Given this list of marker genes CRYAB, MAGI2, IGFBP7, ACSM3, CDH1, MPC2, KCTD12 (potassium channel tetramerization domain containing 12), KRT19, TPST1, OXCT1, LLGL2, CAV2, REEP5, MECOM, TEK, FUCA1, LYN, CX3CL1, ATP5MG, ACOT2, SLC22A5, SLC30A1, ETS2, CLU, ALDH6A1, NCOA3, IFIT1, GADD45A, PEX7, SEMA3C, ZEB2, AKR1C3, LAMP2, DUSP9, RAB22A, SYNGR2, CDH5, IL27RA, TACSTD2, HOXD8, SERPINF1, S100A10, LEPROT, KAZN, PDXK, PMP22, GNG12, DST, COL1A2 (NCBI Gene Id 1278), MYOF, DSTN, MAF, PATZ1, FGFR3, FPGT, TRAM2, CLDN3, MTMR6, RGL1, MAN2A1, PGRMC2, TNFAIP8, SELENOP, ERG, ALDH4A1, ELF1, CTSH, ITM2B, NR3C1, GNAI1, THSD7A, CRIM1, TMED5, IQCK, PDE8A, SERINC5 (serine incorporator 5), TCF21, PRNP, RBPMS, SMPDL3A, PPP2R5A, KIF13B, IL10RB, TGFBR2, ZNF44, ALDH1A1, ST3GAL6, ANK3, PLCG2, CTSO, SPP1, GPRC5B, IQGAP1, CPVL, MITF, ATP10D, AGRN, TSPO, TBC1D9, SLC37A4, PDZRN3, PPP1R3C, BPGM, OLFML2A, APOE, PRCP, DAB2, KIFC3, MYLK, ALCAM, HPN (NCBI Gene Id 3249), SEPHS2, LRRC32, EFR3A, TRIM2, APOM, PLS1, FRY, PLAU, SLC35A3, PODXL, SCP2, PRPS2, COL4A5, VEGFA, CA12 (carbonic anhydrase 12), MERTK (MER proto-oncogene, tyrosine kinase), ERBB4, AXL, CRADD, AHNAK, TOM1L1, IMPA2, CTDSPL, DYNC2LI1, MXRA8, KDR, BLVRB, PPL, SP100, CDKN1C, TGOLN2, ZNF124, LDB2, ANGPT1 (angiopoietin 1), PLS3, CRYZ, ATP1B1, ENPEP, PDE6B, XBP1, IL1R1, RIDA, TFPI, HERPUD1, MSMO1, SDHD, TOB1, MYH9, GLUD2, ANXA4, ASAH1, PLPP1, VLDLR, CD2AP, AMOTL2, CDS1, CAST, GNG11, UGCG, FGF9, CEBPD, CYB5A, ACSL1, CARD10, FAM3C (NCBI Gene Id 10447), IQGAP2 (NCBI Gene Id 10788), MATN2, CREBL2, GUCY1A1, ANXA3, ITPRID2, ATP1A1, here is a description of the gene set: Genes up-regulated in Wilm's tumor samples compared to fetal kidney. from publication Li CM, Guo M, Borczuk A, Powell CA, Wei M, Thaker HM, Friedman R, Klein U, Tycko B (PMID 12057921) studied in species Homo sapiens Human Gene Set: LI_WILMS_TUMOR_VS_FETAL_KIDNEY_1_UP Wilms' tumor (WT) has been considered a prototype for arrested cellular differentiation in cancer, but previous studies have relied on selected markers. We have now performed an unbiased survey of gene expression in WTs using oligonucleotide microarrays. Statistical criteria identified genes as differentially expressed between WTs and fetal kidneys. This set contained 124 matches to genes on a microarray used by Stuart and colleagues (Stuart RO, Bush KT, Nigam SK: Changes in global gene expression patterns during development and maturation of the rat kidney. Proc Natl Acad Sci USA 2001, 98:5649-5654) to establish genes with stage-specific expression in the developing rat kidney. Mapping between the two data sets showed that WTs systematically overexpressed genes corresponding to the earliest stage of metanephric development, and underexpressed genes corresponding to later stages. Automated clustering identified a smaller group of genes that were highly expressed in WTs compared to fetal kidney and heterologous tumor and normal tissues. This signature set was enriched in genes encoding transcription factors. Four of these, PAX2, EYA1, HBF2, and HOXA11, are essential for cell survival and proliferation in early metanephric development, whereas others, including SIX1, MOX1, and SALL2, are predicted to act at this stage. SIX1 and SALL2 proteins were expressed in the condensing mesenchyme in normal human fetal kidneys, but were absent (SIX1) or reduced (SALL2) in cells at other developmental stages. These data imply that the blastema in WTs has progressed to the committed stage in the mesenchymal-epithelial transition, where it is partially arrested in differentiation. The WT-signature set also contained the Wnt receptor FZD7, the tumor antigen PRAME, the imprinted gene NNAT and the metastasis-associated transcription factor E1AF.